The following is a description of a gene set: Human Gene Set: GOMF_CARBOXYLIC_ESTER_HYDROLASE_ACTIVITY Catalysis of the hydrolysis of a carboxylic ester bond. studied in species Homo sapiens, and this is the list of marker genes: DTD2, ACOT12, LPL, LIPE, AADAC, PNPLA4, SIAE, NOTUM, CLC, ABHD10, PLA1A, LIPA, DAGLA, PNPLA3, CES4A, PLA2G5, PLA2G7, PLAAT5, AADACL4, CES5A, PLB1, PLAAT2, ENPP2, PAFAH1B2, GDE1, ABHD1, PNLIPRP1, PTRH1 (peptidyl-tRNA hydrolase 1 homolog), ACOT2, FAAH, ACHE, PNPLA7, APOA5, MRPL58 (NCBI Gene Id 3396), LYPLA2, PON3, PNPLA5, ABHD15, DTD1, ABHD2, LIPK, ABHD4, LCAT, NDST2, CA2, ABHD12, PLA2G6, PLA2G4A, AADACL3, LDAH, CES1, LIPN, LYPLAL1, ACOT6, APMAP, PLA2G4D, MACROD2, ESD, PNPLA6, CES3, CASP3, PNLIP, PGAP1, CA1, PGAP6, PLA2G2D, PON2, ABHD12B, PLAA, APOC2, LGALS13, PLA2G2A, GDPD1, H6PD, MACROD1, PLA2G10, DAGLB, PTRH2, PRDX6, PAFAH2, RGN, ABHD16A, CHKA, PAFAH1B3, ACOT1, SCGB1A1, PLA2G4C, GPIHBP1, PLA2G12B, PLA2G2E, ALDH2, PON1, CES2, PLA2G4F, ABHD16B, LIPM, ASPG, ETF1, PNLIPRP2, ACOT11, ENSG00000293349, PLA2G4E, APOH, NCEH1, AADACL2, PLA2G1B, PNLIPRP3, PLAAT1, ABHD6, BPHL, PLA2G12A, NDST1, ABHD8, BCHE, LIPG, LIPF, TNFAIP6, PGLS, LIPH, OARD1, LIPC, ABHD5, DPH7, LIPI, CEL, ACOT4 (NCBI Gene Id 122970), PLAAT3, PLA2R1, AOAH, PLA2G2F, OC90, ABHD3, ABHD11 (NCBI Gene Id 83451), ADPRS, ACOT9, ACOT8, GDPD3, PLA2G4B (NCBI Gene Id 100137049), ANXA1, MGLL, ACOT7, BAAT, PNPLA8, PPME1, PROCA1, ANXA8, LYPLA1, PNPLA1, ANXA3, NDST3, PNPLA2, ANXA2, PTRHD1, PLAAT4, DDHD2, PLA2G15, RPE65, PLA2G2C (phospholipase A2 group IIC), PLA2G3, DDHD1